The following is a description of a gene set: Human Gene Set: KEGG_MEDICUS_REFERENCE_ACH_CHRN_RAS_ERK_SIGNALING_PATHWAY studied in species Homo sapiens ACH-CHRN-RAS-ERK signaling pathway. Pathway ID: N01343. Pathway type: Reference. Pathway class: nt06210 ERK signaling. Pathway Definition from KEGG: ACh -> CHRNA7 -> Ca2+ -> RAS -> RAF -> MEK -> ERK -> CREB, and this is the list of marker genes: CREB3L3, CHRNA7, ATF4, ATF2, NRAS, CREB3L2, CREB3L1, MAP2K1, HRAS, MAPK1, BRAF, ATF6B, CREB3, CREB1, MAP2K2, ARAF, RAF1, CREB3L4, MAPK3, KRAS, CREB5